The following is a description of a gene set: studied in species Homo sapiens Human Gene Set: GSE13485_PRE_VS_POST_YF17D_VACCINATION_PBMC_DN from publication Querec TD, Akondy RS, Lee EK, Cao W, Nakaya HI, Teuwen D, Pirani A, Gernert K, Deng J, Marzolf B, Kennedy K, Wu H, Bennouna S, Oluoch H, Miller J, Vencio RZ, Mulligan M, Aderem A, Ahmed R, Pulendran B (PMID 19029902) Genes down-regulated in comparison of peripheral blood mononuclear cells (PBMC) before vs after YF17D vaccination., and this is the list of marker genes: FGL2, RPE, PARP9, IFI44, USP18, GSS, OAS1, BTN3A3, PMM2, FAM13A, IDE, SMCO4, MX2, IFI35, PLXNC1, STAT2, IFIT1, SIGLEC1, IFI27, FCGR1BP (NCBI Gene Id 440607), HADH, PLAC8, FOSL1, MTHFD1, ATP10D, APOBEC3A, PSME2, RTCB (RNA 2',3'-cyclic phosphate and 5'-OH ligase), TLR8, PARP12, IFI6, SLAMF7 (SLAM family member 7), CXCL11, LAP3, SPATS2L, CMPK2, LY6E, ECHDC1, STAT1, C2, SCO2, COA3, GAPT, PDHA1, IPO8, SCARB2, GBP1, MYD88, FCGR3B, PARP14, DPAGT1, OAS2, SIDT2, SAMD9, MBNL3, GLCE, PRPSAP1, LAMP3, GOT2, RB1, SLC43A3, HDHD2, VPS35, IFIH1, BLVRA, ZDHHC16, TMEM154, XAF1, PIP4K2B, BAAT, ACSL5, SLC27A3, EPSTI1, PNPT1, LINC00487, CX3CR1, KIF16B, SAMD9L, DYNC1I2, JPT2, CKMT2-AS1, C3AR1, TMT1A, IMMT, FIG4, UFSP2, IRF9, LGALS9, DDX60, SNTB1, RIGI, CBX1, MSRB1 (NCBI Gene Id 51734), SRBD1, TRIM5, TAP1, IFITM3, DDX60L, DHX58, CYP1A2, TCF7L2, VPS45, CXCL10, GTF2H1, ACAD9, SAMHD1, MVB12A (NCBI Gene Id 93343), HERC5, MEGF9, VSIG10L, ATP6V1D, C1QA, BST2, WDR70 (NCBI Gene Id 55100), SAC3D1, RTP4, FANCL, TRIM22, EFL1, ISG15, GPBAR1, TNFSF13B, IFNAR1, MS4A4A, LAIR1, LINC03086 (NCBI Gene Id 649786), CPPED1, RALB (NCBI Gene Id 5899), MSR1, AIM2, MX1, ANXA2 (annexin A2), SAMD4A (sterile alpha motif domain containing 4A), UBTD2, BTK, GTPBP2, CNP (2',3'-cyclic nucleotide 3' phosphodiesterase, NCBI Gene Id 1267), JPH4 (NCBI Gene Id 84502), ZBP1, GNPDA1 (glucosamine-6-phosphate deaminase 1), PIN4, OAS3, ADAR, C1orf162, SERPING1, CREBL2, SMARCAL1, KMO, IFI16, RCAN1, ANKRD22, OASL, SP110, TRIM69, RGL1, DTX3L, SMC1A, KIAA1958, IFITM2, COX10, ERICH3, ADA2, LGALS3BP, HSDL2 (NCBI Gene Id 84263), IDH1, RSAD2 (NCBI Gene Id 91543), EIF2AK2, ELP3, MARCHF1, DNAJC13, BATF2, MYOF, KLHDC7B, IFIT3, IRF7 (NCBI Gene Id 3665), TDRD7, DECR1, PSMB8, TIMELESS, GBA1LP, ALDH3A2, STAMBP, PARP10, HERC6, VRK2, UBE2L6, CYSLTR1, ADAP2, ACP2, SNAPC3, IFITM1, ELP4, MARCKS, IFI44L, MTMR12, PIK3AP1, IFIT2 (NCBI Gene Id 8375), RAD50, DNAJC16